Given this list of marker genes ALOX5AP, RACK1, ANAPC13, ZNF337, PSMB4, TSFM, YWHAZ (tyrosine 3-monooxygenase/tryptophan 5-monooxygenase activation protein zeta), RPLP0, DCTD, FTH1, RPS29, HIPK1, DHX9, ACTB, SARS1, VAV1, PTGER2, CPNE1, PCF11, ACO2, NCOR2, EMG1, CAD, TOP2B, HYOU1, LAMTOR5, RPL35, PA2G4, MAN2A2 (NCBI Gene Id 55485), BMS1, RAD23A, TXNL4A, SAT1, STAT4, TAF7, MICAL2, PRKAR1A, DAP3, PSMA2, BPHL, PPM1A, MBOAT7, LRP10, GSPT1, STXBP1, STK19, LAMP2, JUND, AASDHPPT, RPL19, VAMP5, TUBGCP2, CDIPT, EIF3F (eukaryotic translation initiation factor 3 subunit F), HBEGF, LMO1, TIMM17A, IPCEF1, IL2RG, ITGB1, PRMT1, RGS2, TXN, H2BC12, CAMKK2, TAPBP, SYNCRIP, CTSD, NUMB, EEF1B2, CLEC11A, CTSK, RPL11, NDUFB5, KLHL21, TRIM58, TFRC, IKBKE, PIK3R1, FLT3LG (fms related receptor tyrosine kinase 3 ligand), SF3B4, RPL23, CUL4B, NUBP1, IK, PPP1R15A, BTN3A2, MTMR1, AGL (amylo-alpha-1, 6-glucosidase, 4-alpha-glucanotransferase), H4C3, PSMA5, PSMA4, PTPN11, LST1, MAGED1, CHD3, CGB3, MYD88, ANP32B, STK38, H3P37, CAPZB, LSM2, PSMD9, ARHGAP1, ZPR1, ARID5A, SF1, KLF6, MORC3, DEDD, HAX1, VDAC1, TMED2, OGT, RPS23, PECAM1, PLIN3, SRRM1, RBPJ, SRSF3, SRSF8, SMARCE1, UBE4A, NSD2, MAP2K1, URI1, UGCG, ZNF384, ATP5MC1, CLTC, TRAF3IP3, IMMT, RSU1, UBE2I, OAT, CD58, CLU, SATB1, WIPF2, PHF2, PRPS1, LGALS9, TMCC1, BICD2 (BICD cargo adaptor 2), ATP5F1A, CCT7, OXA1L, RPS20, AHNAK, RPN1, SETD1A, NELFB, CYC1, here is a description of the gene set: Genes upregulated in peripheral blood lymphocytes (PBL) from patients with well functioning kidneys more than 1-year post transplant compared to those from normal living kidney donors. species: Homo sapiens A major challenge for kidney transplantation is balancing the need for immunosuppression to prevent rejection, while minimizing drug-induced toxicities. We used DNA microarrays (HG-U95Av2 GeneChips, Affymetrix) to determine gene expression profiles for kidney biopsies and peripheral blood lymphocytes (PBLs) in transplant patients including normal donor kidneys, well-functioning transplants without rejection, kidneys undergoing acute rejection, and transplants with renal dysfunction without rejection. We developed a data analysis schema based on expression signal determination, class comparison and prediction, hierarchical clustering, statistical power analysis and real-time quantitative PCR validation. We identified distinct gene expression signatures for both biopsies and PBLs that correlated significantly with each of the different classes of transplant patients. This is the most complete report to date using commercial arrays to identify unique expression signatures in transplant biopsies distinguishing acute rejection, acute dysfunction without rejection and well-functioning transplants with no rejection history. We demonstrate for the first time the successful application of high density DNA chip analysis of PBL as a diagnostic tool for transplantation. The significance of these results, if validated in a multicenter prospective trial, would be the establishment of a metric based on gene expression signatures for monitoring the immune status and immunosuppression of transplanted patients. from publication Flechner SM, Kurian SM, Head SR, Sharp SM, Whisenant TC, Zhang J, Chismar JD, Horvath S, Mondala T, Gilmartin T, Cook DJ, Kay SA, Walker JR, Salomon DR (PMID 15307835) Human Gene Set: FLECHNER_PBL_KIDNEY_TRANSPLANT_OK_VS_DONOR_UP